Given this list of marker genes CCDC68 (coiled-coil domain containing 68), TRIM16, GIPC2, TPD52, CARD10, MMP1, CLEC1A, CSF2RB, GIMAP5, NRN1, JAG2, MYCT1, TSPAN12, SH2B3, HOXB7, NR5A2, IL15, FLI1, SMAGP, GMFG, HLA-DRA, THBD, SOCS2, TMEM70, S1PR1, FNBP1L, HCP5, PKP4, IL18R1 (NCBI Gene Id 8809), ENG, JCAD, CA4, LMO2, SELE, PRKCH, CAVIN2, MAST4, SOX17, PITPNC1 (NCBI Gene Id 731962), AREG, SCHIP1, GARRE1, CYTH1, MYO10, RND1, HLA-B, RASIP1, PODXL, HLA-DMA (NCBI Gene Id 3108), CD320, ADGRG1, HLA-DPB1, LAPTM5, CD74, F11R, VWF, STC1 (stanniocalcin 1), CLIC5, PCDH17, ETS2, SSH1, GIMAP4, DOCK9 (NCBI Gene Id 23348), MCF2L, MET, PTPRM, ABLIM3, LHX6, THSD7A, SRGN, PLA1A, DUSP6, LPCAT4, PNP, MYRIP, MGST2, GNG11, XAF1, TACSTD2, TGM2, CCRL2, RASA4 (NCBI Gene Id 10156), MECOM, PECAM1, DNM3 (NCBI Gene Id 26052), CAPN11, G0S2, CD2AP, SCARF1, TIE1, IFI27, HLA-DQB1, SPTLC2, HHEX, PALM2AKAP2, EPHB4, DSG2, SLCO4A1, MCTP1, CTSH, IGLC2, ICAM2, ARAP3, RAMP3, KL, CARD8, SHB, WARS1, ABCG1, PTPRB, MEOX1, SEMA6A, KDR, STX11, PTPRE, CD93, TM4SF1, UPP1, IL3RA, GATA2, EMCN, PIK3R3, ICA1, TBC1D9, RAPGEF5, PALMD, JAM2, PLVAP, BAALC, FLT1, EFNA1, IRAG2, TNFRSF1B, PGS1, KANK3, CSF3, NOTCH4, MPZL2, APLNR, SCUBE2, NLK, PIK3C2B (NCBI Gene Id 5287), TBC1D30, HLA-DQA1, ALDH1A2 (aldehyde dehydrogenase 1 family member A2), HBEGF, IFIH1, CHD7, LIMK2, SELP, GFOD1, NAP1L1, APOLD1, EFNB2, ITGA6, HLA-DPA1, RPS6KA2, KIF25, IFI44L, LPAR6, RASGRP3, PCDH12, CX3CL1, EOGT (NCBI Gene Id 79580), CDC42EP3, ANXA3, RAPGEF4, SEC14L1, CDH5, RNASE1, MMRN2, NEDD9, ENPP4, CFI, ACKR1 (atypical chemokine receptor 1 (Duffy blood group)), SCARB1, SWAP70, TSPAN6, ZNF385D, CLDN5, CDC37, CFLAR, PDE2A, TEK, FAM107A (family with sequence similarity 107 member A), CCL14, LCP2, MYO5C, TSPAN13, HLA-F, SEMA3F, HLA-DRB1, SMAD1 (SMAD family member 1), BCAR3, FABP5, ANGPT2 (NCBI Gene Id 285), SYBU, C1orf115, TSPAN7, ADAMTS9, CREM, ARHGEF15, ADRB2, AQP1, BST2, GIMAP6, ENDOU, ADGRL4, TFPI2, TEX14, KLHL2, ERG, ST6GAL1, TPD52L1, USP36, CDK1, ISG20, RCAN1 (NCBI Gene Id 1827), here is a description of the gene set: species: Homo sapiens Genes down-regulated in freshly isolated CD31- (stromal stem cells from adipose tissue) versus the CD31+ (non-stem) counterparts. from publication Boquest AC, Shahdadfar A, Frønsdal K, Sigurjonsson O, Tunheim SH, Collas P, Brinchmann JE (PMID 15635089) Human Gene Set: BOQUEST_STEM_CELL_DN Stromal stem cells proliferate in vitro and may be differentiated along several lineages. Freshly isolated, these cells have been too few or insufficiently pure to be thoroughly characterized. Here, we have isolated two populations of CD45-CD34+CD105+ cells from human adipose tissue which could be separated based on expression of CD31. Compared with CD31+ cells, CD31- cells overexpressed transcripts associated with cell cycle quiescence and stemness, and transcripts involved in the biology of cartilage, bone, fat, muscle, and neural tissues. In contrast, CD31+ cells overexpressed transcripts associated with endothelium and the major histocompatibility complex class II complex. Clones of CD31- cells could be expanded in vitro and differentiated into cells with characteristics of bone, fat, and neural-like tissue. On culture, transcripts associated with cell cycle quiescence, stemness, certain cytokines and organ specific genes were down-regulated, whereas transcripts associated with signal transduction, cell adhesion, and cytoskeletal +CD105+CD31- cells from human adipose tissue have stromal stem cell properties which may make them useful for tissue engineering.